The following is a description of a gene set: species: Mus musculus Mouse Gene Set: GOMF_CDP_ALCOHOL_PHOSPHATIDYLTRANSFERASE_ACTIVITY Catalysis of the reaction: CDP + alcohol = CMP + phosphatidyl alcohol., and this is the list of marker genes: Ptdss2, Pgs1, Selenoi, Chpt1, Cdipt (NCBI Gene Id 68253), Cept1